The following is a description of a gene set: Mouse Gene Set: CUI_CDC1_GM_CSF_RESPONSE_DN Genes negatively differentially expressed in cell type: cDC1 (conventional dendritic cell type 1) upon treatment with cytokine: GM-CSF in mouse lymph nodes in vivo. from publication Cui A, Huang T, Li S, Ma A, Pérez JL, Sander C, Keskin DB, Wu CJ, Fraenkel E, Hacohen N (PMID 38057668) Cytokines mediate cell-cell communication in the immune system and represent important therapeutic targets. A myriad of studies have highlighted their central role in immune function, yet we lack a global view of the cellular responses of each immune cell type to each cytokine. To address this gap, the authors created the Immune Dictionary, a compendium of single-cell transcriptomic profiles of more than 17 immune cell types in response to each of 86 cytokines (>1,400 cytokine-cell type combinations) in mouse lymph nodes in vivo. A cytokine-centric view of the dictionary revealed that most cytokines induce highly cell-type-specific responses. For example, the inflammatory cytokine interleukin-1β induces distinct gene programmes in almost every cell type. A cell-type-centric view of the dictionary identified more than 66 cytokine-driven cellular polarization states across immune cell types, including previously uncharacterized states such as an interleukin-18-induced polyfunctional natural killer cell state. species: Mus musculus, and this is the list of marker genes: Fuca1, AB124611, Ptp4a2, Cd37, Itm2b, Ifngr1, Themis2, Mxd4, Sat1, Btg2, Unc93b1, St8sia4, Foxp1, Eif3e, Cox7a2l, Ctsh, H2-Oa, Fnbp1, Ifi209, P3h2, Nup210, 9930111J21Rik2, Treml4, Clk1, H2-Q7, Samd9l, Mycl, Tnrc6b, Smpdl3a, Vav3, Tspan13, Rgs2, Eif3f (eukaryotic translation initiation factor 3, subunit F), Pnrc1, Nsa2, Kctd12, Arl5c, Rgs10, Supt4a, Ccr2, Npc2, Mpeg1, Uvrag, Ramp1, Alox5ap (arachidonate 5-lipoxygenase activating protein), Creg1, Itgb7, Gdi2, Pmaip1, Fau, Dusp1, Cd47, Rgs1, N4bp2l1, Laptm5, Itga4, Zfp36l1, Ypel3, Ptpn18, Arid4a, Pold4, Pdcd4, Eef2, Pid1, Septin6, Dennd4a, Parp8, Naca, Serinc3, Pstpip1, Nop53, Man2b1, Jun, Fyb1, Fosb, Erp29, Btg1, Klf2, Fos, Eef1b2, Cd81, Arhgap15, Fgl2, Trim7, Tsc22d3, Lyz2, Igbp1 (NCBI Gene Id 97609), Pfdn5, Pld4